Given this list of marker genes PCBP1, KLHDC3, GIT2, ENG, CALHM2, PFKFB4, PRR13, PLEKHO2, NFIC, PSAP, ELOVL1, BRI3 (NCBI Gene Id 25798), APOBR, PHC2, RAB31 (NCBI Gene Id 11031), RANBP6, TNFAIP8L2, ORAI3, SERTAD3, NAGS, STX6, CTSH (cathepsin H), ARL3, TFEB, TMEM101, FRAT2, ICMT, CENPB, LAMTOR2, PHF23, GLTP, PIK3CD, TGFBI, MTCH1, INTS9 (NCBI Gene Id 55756), PPP1R9B, KLHDC10, CXCL16, DAGLB (diacylglycerol lipase beta), UNC45A, RUNX3, DDX17 (DEAD-box helicase 17), CORO1A, USP19, SASH3, UBAC1, MAST3, GRN, DGKZ, CTDSP2, NLRP12, NUDT16L1, NT5DC2, RAB11FIP4, TSC22D3, EXTL3 (exostosin like glycosyltransferase 3), RGS12, LAPTM5, ENC1, DSTYK, ARHGAP30, PRELID1, CSF1R, ZNF688, IL27RA, NACC2, THAP11, ARAP1, RAB5IF, TCF20, RAB29, VPS35, RGS19, CDC34, ARHGAP27, PTP4A2, SPIDR, TTC7A, B4GALT3, STK11, CLIC1, DUSP7, CSK, TMEM121B, TYROBP, STX7, HHEX, TWF2, SUMO2, LGALS1, SDHA, PLIN3, TACC1, TNFRSF10D, MPEG1, NELFA (negative elongation factor complex member A), SMARCAL1, APBB1IP, TACC3, ANKRD13D, CX3CR1, VMO1, CXCR4, DNAL4, RPS6KA1, JUND, PHAF1, USP22, GABARAP, ARHGAP45, FAM89B, RPL27, DIS3L, GLUL, CASP8, PAGR1, EMSY, SETD1B, DYNLL1, RAP2B, WBP1L, COTL1, BAZ1B (bromodomain adjacent to zinc finger domain 1B), CTDSP1, PURA, FAM78A, BMF, TMEM170B, PIP5K1C, SNX3, CCR2, GSTP1, ACP5, TIMP2, ARHGAP22, TNRC6A, ARRDC2, EVI2A (NCBI Gene Id 2123), ATF5, S100A11, ZNF511, BRD3, MPG (N-methylpurine DNA glycosylase), STK24, SH2D3C, KLF13 (NCBI Gene Id 51621), GID4, ATOSB, TMBIM1 (NCBI Gene Id 64114), RARA, SNX27, ZNF740, DOK2, FRAT1, TRAPPC12, ZDHHC7, NCKAP5L, PLEKHO1, RAB8A, PLXNB2, ATXN7L3, IFFO1, NCOR2 (nuclear receptor corepressor 2), LYL1, DCAF12, HECA, CYTIP, ATP6V0E1, ATG9A, RHOG (ras homolog family member G), PPP1CA, MLXIP, IFI30, MAP7D1, ARL6IP5, TGIF2, MYO1F, TNFRSF1A, POU2F1, TLR1, WIPI2, TCHP (trichoplein keratin filament binding), WDR44 (WD repeat domain 44), DCLRE1C, ZNF467, ARPC1B, CMTM3, ARHGAP1, OTULINL, ZBTB11-AS1, PGP, NLRC4, MAP3K3, PCBP2, MR1, PPP1R18, SH3GL1, CHAMP1, here is a description of the gene set: Genes down-regulated in comparison of monocytes treated with 1 ng/ml LPS (TLR4 agonist) versus untreated monocytes. from publication Dower K, Ellis DK, Saraf K, Jelinsky SA, Lin LL (PMID 18292579) species: Homo sapiens TREM-1 is an orphan immunoreceptor expressed on monocytes, macrophages, and neutrophils. TREM-1 associates with and signals via the adapter protein DAP12/TYROBP, which contains an immunoreceptor tyrosine-based activation motif (ITAM). TREM-1 activation by receptor cross-linking is pro-inflammatory, and can amplify cellular responses to Toll-like receptor (TLR) ligands such as bacterial lipopolysaccharide (LPS). To investigate the cellular consequences of TREM-1 activation, we have characterized global gene expression changes in human monocytes in response to TREM-1 cross-linking in comparison to and combined with LPS. Both TREM-1 activation and LPS up-regulate chemokines, cytokines, matrix metalloproteases, and PTGS/COX2, consistent with a core inflammatory response. However, other immunomodulatory factors are selectively induced, including SPP1 and CSF1 (i.e., M-CSF) by TREM-1 activation and IL-23 and CSF3 (i.e., G-CSF) by LPS. Additionally, cross-talk between TREM-1 activation and LPS occurs on multiple levels. While synergy in GM-CSF protein production is reflected in commensurate mRNA abundance, comparable synergy in IL-1b protein production is not. TREM-1 activation also attenuates the induction of some LPS target genes, including those that encode IL-12 cytokine family subunits. Whereas positive TREM-1 outputs are abolished by the PI3K inhibitor wortmannin, this attenuation is largely PI3K-independent. These experiments provide a detailed analysis of the cellular consequences of TREM-1 activation, and highlight some of the complexity in signal integration between ITAM- and TLR-mediated signaling. Human Gene Set: GSE9988_LPS_VS_VEHICLE_TREATED_MONOCYTE_DN